The following is a description of a gene set: Here we show that tumor necrosis factor (TNF) induced in human T-regulatory cells (Treg), as compared to conventional T cells (Tcon), a transcription program highly enriched for typical NF-κB target genes, such as: the cytokines LTA and TNF; the TNF-receptor super family members FAS, 4-1BB and OX-40; various anti-apoptotic genes; and other important immune-response genes. As an initial approach to examine the cellular program induced by TNF in Tregs versus Tcon cells, we employed microarray gene expression analysis at 2 and 24 hrs following TNF treatment. Genes up-regulated in T reg cells (2h): medium versus TNF. Human Gene Set: GSE18893_CTRL_VS_TNF_TREATED_TREG_2H_UP from publication Nagar M, Jacob-Hirsch J, Vernitsky H, Berkun Y, Ben-Horin S, Amariglio N, Bank I, Kloog Y, Rechavi G, Goldstein I (PMID 20181891) studied in species Homo sapiens, and this is the list of marker genes: ZNF503, SLC23A2, GNG10, PPIF, ATXN2, DNAJC28, ELMOD3, AKT3, CACUL1, ARHGDIA, SPATA13, SAR1A, SEPTIN2, ATL3, MAGEE1, ZNF260, SLC25A51, UXT, FYTTD1, S1PR2, PAPSS1, UBE2Q1, PDE5A, DGLUCY, TSPAN31, VWA5A, RNF220, DDI2, DENND11, SDCCAG8, SNX19, CD200R1L, MKNK2, CLOCK, CERS6 (ceramide synthase 6), BMP2K, JUN, GPAT3, APC, CDK19, HOMER1 (homer scaffold protein 1), LPP, TCF4, SMPDL3A, SDF4, REXO2, CHPT1, TRIM3, DEXI, F5, MINDY2, STX16, PURA, TRIO, AAK1, PHC3 (NCBI Gene Id 80012), ZBTB20, MTPN, VIM, PRKX, ITGB1, SHOX2, CNST, PHF8, ERLEC1, NHERF4, GMCL1, GTF3C6, TMED4, PPARD, FNBP1, EVA1B, FAM174A, SRP54, PURB, SMARCD1, LEPROT, KLF7, ABL2, DAG1, ACADSB, APOOL, SESN3, RCOR3 (NCBI Gene Id 55758), EEF1G, RCN2, SLC15A4, CBX1, FAM3B (FAM3 metabolism regulating signaling molecule B), CHD3, TWSG1, BRPF3 (NCBI Gene Id 27154), EXOC6B, UHMK1, ARL1, UBR5, PRKAR2B, SECISBP2L, MAGI1, ZFAND3, CIAO2B, PTPN22, BCL7B, RBM45, TTC4, ELK4 (ETS transcription factor ELK4), RHOB, ZNF664, VIRMA, DAND5, MTSS1, GFOD1, RNF187, CTSV, CD93, MEF2A, GDNF, HNRNPH3, ZSCAN26 (zinc finger and SCAN domain containing 26), TAF1, SARAF, ZNF467, NDRG1, HIPK2, ZFTRAF1, EFCAB14, EZH1, CTDSP2, DERL2 (NCBI Gene Id 95558), TBL1X, TREX1, RNPEPL1, SCRG1, SLC33A1, TLR1, IPO11, SLC41A1 (solute carrier family 41 member 1), PIK3R2, ABHD17A, SPART, PI4K2B, CDK8, TRAPPC1, FOXN3, ERN1, ANKRD40, STING1, CBFB, ZBTB41, MBD2, FAM241A, USP48, FAM199X, IL22RA2, APOE, FOXP4, RAC1, SAP30L, MEF2C, GLG1, GNAS, PRKCB, MGLL, ARL5A, MAP4K3, GRK5, PLEKHB2, WDFY2, PRPSAP1, BASP1, SLC36A4, MGAM, YBX1, TAX1BP3, FOXO1, ZMAT3, COX14, SLC9A9, GPX4, SLC41A2, BMPR2, CCS (copper chaperone for superoxide dismutase), PGRMC1, IL1RL1, STARD7, JADE2, MCFD2, SORD, HEXIM1, EAF1, TRIM24, LIFR, TXNDC15, AGO1, PNKD, ILVBL, KCTD12, BBX, P4HA1, LYRM4